The following is a description of a gene set: Human Gene Set: GOCC_CDC73_PAF1_COMPLEX species: Homo sapiens A multiprotein complex that associates with RNA polymerase II and general RNA polymerase II transcription factor complexes and may be involved in both transcriptional initiation and elongation. In Saccharomyces the complex contains Paf1p, Cdc73p, Ctr9p, Rtf1p, and Leo1p., and this is the list of marker genes: LEO1, CDC73, CTR9, RTF1, SKIC8 (NCBI Gene Id 80349), PAF1, PEX2